Given this list of marker genes Nol3, 4930550C14Rik, Bag4, Lrrk2, Siah3, Bag3, here is a description of the gene set: Mouse Gene Set: GOBP_NEGATIVE_REGULATION_OF_PROTEIN_TARGETING_TO_MITOCHONDRION Any process that stops, prevents or reduces the frequency, rate or extent of protein targeting to mitochondrion. studied in species Mus musculus